The following is a description of a gene set: part of: NR1H2 and NR1H3-mediated signaling studied in species Homo sapiens Liver X receptors NR1H3 (LXR alpha) and NR1H2 (LXR beta) are sterol-responsive transcription factors that become activated upon the engagement with their cognate oxysterol ligands. Ligand-activated NR1H2 & NR1H3 induce a genetic program aimed at reducing the cellular sterol load by limiting cholesterol uptake, attenuating cholesterol biosynthesis and promoting cholesterol efflux. 2009; Zhang L et al. 2012). Reactome Pathway: NR1H2 & NR1H3 regulate gene expression to limit cholesterol uptake, and this is the list of marker genes: RXRA (retinoid X receptor alpha), MYLIP, RXRB, NR1H2, NR1H3